Given this list of marker genes Ran (RAN, member RAS oncogene family), here is a description of the gene set: This event has been computationally inferred from an event that has been demonstrated in another species.<p>The inference is based on the homology mapping from PANTHER. Briefly, reactions for which all involved PhysicalEntities (in input, output and catalyst) have a mapped orthologue/paralogue (for complexes at least 75% of components must have a mapping) are inferred to the other species. Reactome Pathway: Transcriptional regulation by small RNAs part of: Gene Silencing by RNA electronically inferred by orthology from the curated human pathway species: Mus musculus